Given this list of marker genes CKAP2, RFC3, CHRNA9, CDC45, DNAI4, POU6F1, OSTM1, RPA3, PCNA, SYTL3, CDCA3, MACIR, SLBP, RMND5A, CDCA5, RUVBL1, TOP2A, RFXAP, MR1, SPO11, SLC6A19, DUT, SLC16A5, EXO1, STAP1, CENPP, NUSAP1, PBK, GTF2H4, IFNGR1, PHF2, NCAPH, CBL, NDC80, DYNLT1, P3H4, ARPP21, GEMIN8, GPSM2, CNOT6, CENPA, SKA2, PHF10, LIPA, SH2D1A, SLC40A1, RFC5, TUBB2A, GMNN, DHRS3, ZNF704, SUV39H1, GZMA, ARSI, TPX2, CEP55, GFI1, H2BC3, TDRD5, ADA, PRIM2, BACH1, DZIP1, CENPE, PRODH, CCNE1 (cyclin E1), MAD2L1, CCNF (NCBI Gene Id 899), MRPL18, P2RY10 (NCBI Gene Id 27334), ESPL1, MDM1, TSPAN2, CDCA2, ETS2, CDKN2AIPNL, BUB1B, TM6SF1, MNS1, TK1, KNL1, CIP2A, DTL, FDPS, GLCCI1, STMN1, SLA2, MPP1, RASL11B, C1GALT1, ARHGAP19, CCNA2, RORC, RAG2, KNSTRN, HMMR, CTH, SLC37A2, PRSS16, ATL2, LDLRAD3, GINS1 (NCBI Gene Id 9837), LY6K, AP3S1, GFRA1, PRICKLE1, MYB, CKAP2L, INTS13, OIP5, MIER1, BIRC5, MBNL3, RCBTB2, EZH2, SGO1, TP53INP1, SSBP2, EDEM1, TICRR, HIBADH, FBLN2, MKI67 (marker of proliferation Ki-67), RTKN2, SHCBP1, APOO, SKA1, CDCA8, DGKE, FBXL12, MTSS1, CXCR4, SYCE2, TENM1, CCL25, KIF20A, ACYP1, PLEKHB1, NUF2, PLXDC1, IFT57, SLC16A1, ALDH7A1, NCAPG, ATP13A3, FKBP5, CD8A, PAX1, TSPYL4, CD8B, CDKN3, PRC1, WDR12, CAMK4, SPC25, TIPIN, FBXO5, MAGI3, CENPF, KIF18B, BMAL1, LIG1, RRM2, CHCHD3, FIGNL1, ERI1, SLC43A1, CAPN3, CENPI, CBY1, RAPGEF3, AURKA, SKP2, PIMREG, AGFG2, SLC35B4, PTCRA, PADI4 (peptidyl arginine deiminase 4), LIG4, BRDT, KIF2C, FXN, ACAA2, ASF1B, CAMK2A, ATAD5, KPNA2, NTN1, IGHM, F13A1, ANXA2, FAM107B, PRKCB, CPA3, ZEB1, MCM6, RACGAP1, EDNRB, GMFG, here is a description of the gene set: species: Homo sapiens from publication Borjesson DL, Kobayashi SD, Whitney AR, Voyich JM, Argue CM, Deleo FR (PMID 15879137) Polymorphonuclear leukocytes (PMNs) were obtained from healthy individuals in accordance with protocols approved by the Institutional Review Board for Human Subjects at the University of Minnesota and the National Institute of Allergy and Infectious Diseases. PMNs (107) were combined on ice with live S. aureus (108) or with live or heat-killed A. phagocytophilum (bacteria isolated from 5x106 infected HL60 cells for a ratio of 1 infected HL60 cell: 2 PMNs, ~ 5-20 A. phagocytophilum: PMN) in wells of a 12-well tissue culture plate (pre-coated with 20% autologous normal human serum). Unstimulated control assays received either buffer (for S. aureus comparisons) or clarified HL60 lysate (for A. phagocytophilum comparisons). Plates were centrifuged at 350 x g for 8 min at 4oC to synchronize phagocytosis and incubated at 37 deg. C in a CO2 incubator for the indicated times. At the indicated times, tissue culture medium was aspirated from the plate and PMNs were lysed directly with RLT buffer (Qiagen, Valencia, CA). Purification of PMN RNA and subsequent preparation of labeled cRNA target was performed as described in Methods. Labeling of samples, hybridization of cRNA with HU133A oligonucleotide arrays (Affymetrix, Santa Clara, CA), and scanning were performed according to standard Affymetrix protocols ( http://www.affymetrix.com/pdf/expression_manual.pdf ). Experiments were performed in triplicate, using PMNs from three healthy individuals for each treatment. Human Gene Set: GSE2405_S_AUREUS_VS_UNTREATED_NEUTROPHIL_DN Genes down-regulated in polymorphonuclear leukocytes (9h): S. aureus infection versus control.